Given this list of marker genes BTG1, STAG3, RAB11FIP5, ADCY6, TSC22D3, CDC40, MAP3K3, TCTN1, NEUROD1, CHL1, ANXA10, DPEP2, PIGL, ATP6V0E2, CBL, FOXO1, ZBTB25, ARID1A, RASGRP2, PCDH9, NRIP1, PVRIG, ETS2, TNFSF11, TGIF1, MMP8, KAT6A, PIK3CD, SPTAN1, DEK, TRPC6, OCA2, CTAGE1, STAT5B, MMP20, COL6A3, GABBR1, CLDN18, IRF8, ODAD2, RPL26, KYNU, FLNB, CD1C, PTPRJ (NCBI Gene Id 5795), CDC42SE1, GGA2 (golgi associated, gamma adaptin ear containing, ARF binding protein 2), PDE4D, MFAP5, FPR3, INHBE (NCBI Gene Id 83729), ZNF83, CST8, NTRK2, FYN, RUBCNL (NCBI Gene Id 80183), TRAF5, SMR3B, KPNA5, PTGS1, SYBU, TNFAIP6, MARCHF1, TBC1D4, DLL3, MARCHF3, RPL27, SNX10, CBLB, RPL17, TRIM68, AP3M2, HGSNAT, PRKAR2B, PHC1, LY86, GCA, RPS23, ECHDC2, KLHL2, GPR137, DGKI, SATB2, PIKFYVE, WDR48, PAWR, SOSTDC1, PDE8B, SLC46A3, HLA-DPB1, STX6, RPL32, C2CD3, NLRP3, KLHL18, MTARC2, MNT, FLCN, RPL13, MAPRE2, PRDM4, LEFTY1, ZNF532 (NCBI Gene Id 55205), IFNA17, NOS1, OGA, NRXN1, SOBP, KATNA1, ZNF345, TBC1D5, MAP7D3, RIN3, MYO10, TMEM30B, LYST, WDR77, CEP164, MAOB, CD83, MORC3, RET, OR11A1 (NCBI Gene Id 81411), PRDM2, MEP1A, SYNPO, LHPP, GSAP (NCBI Gene Id 54103), PCDHGB5, RNF44, CBX7, DYNC2H1, ITGA9, GUCY1A1, ALOX5AP, FRY, ZNF480, MAP1A, CLMN, DNASE2B, SYCP2, DDR1, SLC25A37, CAP2, SRR (serine racemase), CRYBG1, BANK1, DTX4 (NCBI Gene Id 23220), CORO2B, TTC9, OR6A2, OCLN, CD22, OBI1, TNFSF12, RNF141 (NCBI Gene Id 50862), MYOC, UVRAG, GCNT1, DGCR8, RGS17, CSF2RA, CAPG, HUWE1, PNISR (NCBI Gene Id 84956), RPL37, ABCA12, TBC1D19, ARHGAP45, CD72, GATM, KCTD7 (NCBI Gene Id 154881), EBI3, ATM, NOTCH2, CXCR4, PARP12, BAIAP3, ZSCAN18, RAB11FIP1, VAMP2, RIPOR2, ATG14, DDX60, VAV3, RSBN1 (NCBI Gene Id 54665), CR2, DNAJB4, GEMIN4, SPRY1, UTP25, ZCCHC2, TSC22D1, TRAK1, BRD3, FBXO38, LAPTM5, SP110, PAX5, here is a description of the gene set: from publication Abbas AR, Baldwin D, Ma Y, Ouyang W, Gurney A, Martin F, Fong S, van Lookeren Campagne M, Godowski P, Williams PM, Chan AC, Clark HF (PMID 15789058) Genes up-regulated in comparison of memory IgG IgA B cells versus blood plasma cells. Immune cell-specific expression is one indication of the importance of a gene's role in the immune response. In order to identify such patterns, we set out to broadly profile gene expression in a variety of immune cells. Human Gene Set: GSE22886_IGG_IGA_MEMORY_BCELL_VS_BLOOD_PLASMA_CELL_UP species: Homo sapiens